Given this list of marker genes HS6ST1, NSMF, SPRY4, GNRH1, DMXL2, FGFR1 (NCBI Gene Id 84151, fibroblast growth factor receptor 1), VAMP7, TACR3, BMP6, LHB, SEMA3A, SMARCE1, HSD3B2, NR0B1, CYP11A1, POR, GNRHR, HFE, BAP1, SLC39A4, GCNA, POLA1, NR5A1, GATA4, AKT1, SMARCB1, NF2, DHX37, MAB21L1, KISS1 (KiSS-1 metastasis suppressor), PROKR2, PROK2, SMO, WDR11, B4GALNT1, FANCM, RBM28, FGD1, LEPR, NHLH2, CYP17A1, DUSP6, SOX9, LEP, TRAF7, FEZF1 (FEZ family zinc finger 1), DCAF17, LGR4, CYB5A, FGF8, FGF17, NDNF, FSHB, PNPLA6 (NCBI Gene Id 10908), NFKB2, SRY, WWOX, ANOS1, PIK3CA, MAP3K1, CPE, KISS1R, WT1, ZFPM2, DHH, CHD7, SUFU, TERT, PDGFB, TAC3, here is a description of the gene set: species: Homo sapiens Human Gene Set: HP_DECREASED_CIRCULATING_ANDROGEN_CONCENTRATION Decreased circulating androgen concentration A reduction in the blood concentration of an androgen, that is, of a steroid hormone that controls development and maintenance of masculine characteristics. The androgens include testosterone and Dehydroepiandrosterone.